Given this list of marker genes Casp3, Cdkn1b, Cdkn1a, Hexim2, Cdkn2a, Ankrd42, Cdkn2c, Inca1 (inhibitor of CDK, cyclin A1 interacting protein 1), Hexim1, Cdkn1c, Cdkn2d, Kat2b, Cdkn2b, here is a description of the gene set: Binds to and stops, prevents or reduces the activity of a cyclin-dependent protein serine/threonine kinase. Mouse Gene Set: GOMF_CYCLIN_DEPENDENT_PROTEIN_SERINE_THREONINE_KINASE_INHIBITOR_ACTIVITY species: Mus musculus